The following is a description of a gene set: Catalysis of the breakage of a carbon-oxygen bond. Human Gene Set: GOMF_CARBON_OXYGEN_LYASE_ACTIVITY studied in species Homo sapiens, and this is the list of marker genes: PTS, HACD4, CDYL, NAXD, HACD1, CA14, TGDS, NEIL3, HADHB, CA10, ENO4, CYP1A2, ECHS1, CA2, ACO1 (aconitase 1), GMDS, CA4 (NCBI Gene Id 762), APIP, XRCC5, PCBD1, CYP2S1, XRCC6, DGLUCY, HTD2, CA1, NTHL1, POLQ, L3HYPDH, PTGIS, ENOSF1, CBS, NEIL1, ALAD, POLL, TBXAS1, EHHADH, HSD17B4, HADHA, ECHDC3, CA6, OGG1, ETNPPL, CA5A, ALKBH1, TPI1, CA13, NEIL2, RPS3, ALOXE3, PARK7, ACO2, CA11, THNSL2, ENSG00000274276, IREB2, ENO2, FH, CYP1A1, AUH, UROC1, ENO1, CA3, GATD1, CA8 (NCBI Gene Id 767), CA9, POLG, FASN, UROS, CA5BP1, HMGA2, HACD2 (3-hydroxyacyl-CoA dehydratase 2), PCBD2, CA5B, ENO3, CYP1B1, HMGA1, HACD3, CA7, CA12 (NCBI Gene Id 771), POLB